Given this list of marker genes CCDC126, CFAP184, TRIT1, IKBIP, XAGE3, SUV39H2, SLC39A3, SAP30, YOD1, SLC20A1 (NCBI Gene Id 6574), IRAG2 (NCBI Gene Id 650574), MED29, SFN, FRAT2, TFPT, ZNF304 (zinc finger protein 304, NCBI Gene Id 57343), ESS2, GLUL, TMEM115, DNAAF4, ASB1, RNF24, PTPN22, ALB, SLC16A6, SNX29, POLR1A, ZNF211, SHC4, ZBTB26, CHAMP1, OSBP, WDR73, KBTBD7, DOP1A, GZF1, PTPRE, DDX6, MTFR1, DDX24, KLHL8 (kelch like family member 8), ATRN, HAUS8, CELF2, PHF23, SPTY2D1, C15orf61, MEX3B, ENC1, PIP4P2, TBCC, DCAF16, ZYG11B, NSDHL, TRIM35, APAF1, GADD45G (NCBI Gene Id 23575), WDR82, SNAI3, ZNF317, ZNF736, THAP12, TNFSF14, MRFAP1L1, IFFO2, ZNF292, RWDD2A, BRIX1, DDIT3, MANF, CCDC12, RUNX1, UBAC1, EIF4ENIF1, HSF2 (NCBI Gene Id 3298), NDRG1 (N-myc downstream regulated 1), CEP85L, SLC46A2, GOLT1B, USP38, TRERF1, ZBTB21 (NCBI Gene Id 57487), JMY, ZSCAN21, PHF13, MED8, IER5L, RABGEF1, ADNP2, FOSL2-AS1, ZBTB24, MTRFR, GNB1L, UNC45A, ZNF566, ZBTB11, ZKSCAN5, CLP1, DDX20, SLC19A2, ZNF627, DUS2, CETN3, ZNF624, SRRM2, ZYX, EIF3K, LRR1, BAG4 (BAG cochaperone 4), SLBP, LINC03066, PRPSAP2, HMG20A, MRPL10, PCGF1, RPAIN, DSTYK, BTRC, PPP1R8, KAT14, GRPEL2, MSH2, DCUN1D5, SDE2, UBN1, PIAS4, DDIAS, PGBD1, PHAX, MFSD5, SMAD5, PDIK1L, TRIM32, GMPS, WDR46, OR2B2 (olfactory receptor family 2 subfamily B member 2), TADA1, IVNS1ABP (influenza virus NS1A binding protein), ASTE1, SLC35B1 (solute carrier family 35 member B1), ARID3A, ANP32B (acidic nuclear phosphoprotein 32 family member B), RFC1, ATL2, PHF20L1, ZNF223, LINC00466, BRF2, FBXO45, LINC00698, ZNF570, RBM27 (RNA binding motif protein 27), RNF113A, AVPI1, ID2B, SLC16A3, CCNT1 (NCBI Gene Id 904), LYSMD3, SERTAD2, EIF2B2, DNAJC11, TXLNG, INPP1, CTTNBP2NL, SF3B3, POLR1C, ZC3H8 (NCBI Gene Id 84524), PREB, URB2, DDIT4, ZNF609, SLC66A1, DEDD2, CEP192, EMSY, ISY1, ING2, NKIRAS1, ZNF227, DRG1, IRF3, ZFP36L1, VRK1, DCAF4, ZNF420, BCL6, ZNF557, TREML1, PPP1R14B, MTFR1L, INIP, C5orf24, MMS19, RRN3, ZNF141, NAIF1, ZNF331, RAB32, here is a description of the gene set: Human Gene Set: GSE18791_UNSTIM_VS_NEWCATSLE_VIRUS_DC_6H_UP The dendritic cell (DC) is a master regulator of immune responses. Pathogenic viruses subvert normal immune function in DCs through the expression of immune antagonists. Understanding how these antagonists interact with the host immune system requires knowledge of the underlying genetic regulatory network that operates during an uninhibited antiviral response. In order to isolate and identify this network, we studied DCs infected with Newcastle Disease Virus (NDV), which is able to stimulate innate immunity and DC maturation through activation of RIG-I signaling, but lacks the ability to evade the human interferon response. To analyze this experimental model, we developed a new approach integrating genome-wide expression kinetics and time-dependent promoter analysis. We found that the genetic program underlying the antiviral cell state transition during the first 18-hours post-infection could be explained by a single regulatory network. Gene expression changes were driven by a step-wise multi-factor cascading control mechanism, where the specific transcription factors controlling expression changed over time. Within this network, most individual genes are regulated by multiple factors, indicating robustness against virus-encoded immune evasion genes. In addition to effectively recapitulating current biological knowledge, we predicted, and validated experimentally, antiviral roles for several novel transcription factors. More generally, our results show how a genetic program can be temporally controlled through a single regulatory network to achieve the large-scale genetic reprogramming characteristic of cell state transitions. from publication Zaslavsky E, Hershberg U, Seto J, Pham AM, Marquez S, Duke JL, Wetmur JG, Tenoever BR, Sealfon SC, Kleinstein SH (PMID 20164420) species: Homo sapiens Genes up-regulated in comparison of control conventional dendritic cells (cDC) at 6 h versus cDCs infected with Newcastle disease virus (NDV) at 6 h.